Given this list of marker genes LRRC42, ORC4, PTGER2 (NCBI Gene Id 63381), SLC46A1, FAM117A, BIRC3, RNF34, RGL1, OXLD1, PDCD4, STARD13, FAM13A, ATP2B1, NAMPT, SNAPC1, RMI1, GMCL1, C2CD2, SELENOK (selenoprotein K), RNF144B, SETDB2, GRSF1, BCL3, GLCE, NBPF10, KGD4, ST3GAL5, DTX4, KYNU, ZEB2, UBE2D1, SERTAD2, MZT1, ZNF485, GRK3, SLC25A25, BCAR3, CELF1, TBX20, PPOX, GTF2A2, TCP1, IMP3, DYNLL1, NCOA7, SUCNR1, ATG3, TRIM32, PLEK, FBXL3, PTPN2, FOXN2, MNT, BTF3L4, MTMR14, P2RY13, NAA20, GPBP1, RIOX1, CCDC126, SLITRK4, GFOD1, MNAT1, MEPCE, H1-1, THOC1, MINDY2, MIA3, LRRC25, RPP38, NT5C3A, NSL1, EHD4, PTPN4, ANTXR2, SPMIP10 (sperm microtubule inner protein 10), NOD1 (nucleotide binding oligomerization domain containing 1), DDX1, EPOP, SLC39A6, RAB11FIP1, YARS2, HEATR5B, NAIP, MGAT1, AFF1, SLC25A46, IGHG1, ZNF232, PRKRA, PKNOX1, TBRG4 (NCBI Gene Id 9238), PLCXD1, PARP8, SUOX, ZNF319, RBM47, INTS12, PTRH2, RNF125, MSRB1, LMO2, INTS7, NDUFAF4, DYRK2, PDPK1, MBLAC2, GPR183, PPP1R21, ASH2L, ATOSA, TP53RK, MIR17HG, RDH14, RASA2, PLEKHA1, ITSN1, NRP2, RAB9A, IL10RA, NXT1, CD86, WNT5B, DAPP1, MARCHF1, GPBP1L1 (NCBI Gene Id 60313), ZMYND19, NDUFV2, YEATS2, FGD4, DBP, ANKS1A, SNX20, SMC3, PTPRE, BDKRB1, CASP3, MOB3C, TANK, STRAP, PPM1K, PRPSAP2, RSBN1L, PACC1, AAK1, TRIM27, TRERF1 (transcriptional regulating factor 1), RBFA, KTI12, PPTC7, LIN52, DUSP6, PIGX, NRROS, FBXO5, MCM3AP-AS1, ARAP2, ATF2, TRPS1, PTX3, EAF2, CCNJ, NECAP2, MYC, USP46-DT (USP46 divergent transcript), COMMD3, KNOP1, MYCL, MIR3142HG (MIR3142 host gene), AP1S2, ARHGAP1, KIF2A, AP4B1, ARHGAP17, FIG4, NUDT16L2P, GSAP, DOLPP1, PDP1, ARID5B, DCLRE1B, ZC3H12C, PRMT6, TXNL1, CCDC112, ELMO2, XPO6 (exportin 6), CXCL2, ZFP64, BNIP3, CNEP1R1, WWP1, MTMR4, SRPK1, MEGF9, RAB2B, NADK, GLI3, here is a description of the gene set: Human Gene Set: GSE16266_LPS_VS_HEATSHOCK_AND_LPS_STIM_MEF_DN Genes down-regulated in mouse embryonic fibroblasts (MEF): LPS versus LPS and heat shock. from publication Takii R, Inouye S, Fujimoto M, Nakamura T, Shinkawa T, Prakasam R, Tan K, Hayashida N, Ichikawa H, Hai T, Nakai A (PMID 20018623) studied in species Homo sapiens To clarify inflammatory genes whose expression is suppressed at high temperatures, we performed comprehensive analysis of gene expression by using a DNA microarray. Two independent primary cultures of mouse embryo fibroblasts (MEF1 and MEF2) were treated with LPS for 4 hours, or treated with LPS for 4 hours after the pretreatment with heat shock at 42˚C for 1 hour, and we identified genes that undergo more than a 3-fold increase with LPS treatment. Remarkably, genes (86%) underwent less than a 2-fold increase after combined treatments with heat shock and LPS in MEF1 and MEF2 cells.